Given this list of marker genes NR5A1, IGHG2, ZFHX3, PHF6, IGKC, STAT6, TP53, UBAC2, ADGRG2, MAD1L1, MRE11, BRIP1, RAD51C, GCLC, GREM1, SRCAP, RNASEL, RNF43, FAS, CDKN2A, KCNN4, EP300, SLC6A14, VHL, IL12A, RAD51D (NCBI Gene Id 5892), HGD, CCND1 (cyclin D1), DHX37, CHEK2, PSMB8, NAB2, IL23R, NBN, MXI1, HFE, PIK3CA, CEACAM6, STAT4, SRY, COL14A1, BRCA1, SLC9A3, AAGAB, EPHB2, NTHL1, APC, STX1A, HLA-B, IL10, RAD51, C4A, SLC11A1, CREBBP, LYN, CCR1, CEACAM3, GSTM3, UNG, PRTN3, AR, BRCA2, KLF6, HLA-DPB1, FOXE1, CFTR, IL12A-AS1, MEFV, TLR4, KLRC4, TGFB1, DCTN4, BARD1, RAD50, HNF1B, MIF, CLDN2, HLA-DPA1, MDM2, BMPR1A, EDNRA, PALB2, SERPINA1, PTEN, IFNGR1, SOX9, CLCA4, ERAP1, PTPN22, HMOX1, BTK, DHH (desert hedgehog signaling molecule), SLC26A9, CTLA4 (cytotoxic T-lymphocyte associated protein 4), here is a description of the gene set: Abnormal male internal genitalia morphology An abnormality of the male internal genitalia. studied in species Homo sapiens Human Gene Set: HP_ABNORMAL_MALE_INTERNAL_GENITALIA_MORPHOLOGY